Given this list of marker genes DRD2, GABRB2, GABRB3, HRH1, DRD4, GABRB1, RAB44, GABRG2, CRACR2A, DIAPH1, DRD3, here is a description of the gene set: Any process that results in a change in state or activity of a cell or an organism (in terms of movement, secretion, enzyme production, gene expression, etc.) as a result of a histamine stimulus. Histamine, the biogenic amine 2-(1H-imidazol-4-yl)ethanamine, is involved in local immune responses as well as regulating physiological function in the gut and acting as a neurotransmitter. Human Gene Set: GOBP_RESPONSE_TO_HISTAMINE species: Homo sapiens